Given this list of marker genes Tssk1, Hspd1, Calcr, Gabra2, Klk5, Pam, Exoc3l, Ntf3, Clca1, Atm, Tbc1d21, Hilpda, Resp18, Ccl28, Dynll1, Stx7, Rab27b, Itgb2l, Dennd4c, Serpine1, Stx4a, Stxbp3, Klk1b9, Klk1b27 (NCBI Gene Id 56855), Septin6, Usp8, Defa30, Dvl1, Spata31, Stx12, Elane, Sytl4, Pomc, Slc17a7, Ap2a2, Tsc22d4, Flot2, Rac1, Htr1d, Ecrg4, Ace3, Tmprss4 (NCBI Gene Id 214523), Slc18a3, Krtdap, Amph, Slc30a3, Defa40, Slc35f1, Brsk1, Lyz1, Syndig1, Dlg1, Atp6v0a2, Abhd2, Cav2, Rab7, Knl1, Prkaca, Crh, Spink5, Syt6, Tssk2 (testis-specific serine kinase 2), Txndc8, Rab14, Slc2a13, Hexa (NCBI Gene Id 15211), Sytl1, Try5, Aph1a, Klk1b8, Ddc, Klk11, Mtmr2 (myotubularin related protein 2), Adam2, Pcsk1n, Tmed2, Nos1, Defa36, Eppin, Scnn1a, Catsper3, Iqub, Atg9a (autophagy related 9A), Klk1b3, Tmem190, Cadm1, Brca2, Otof, Atp6v1b1, Slc11a1, Pde4b (NCBI Gene Id 97194), Cep131, Septin14, Igf1, Scg3, Gal, Semg1, Rab8a, Lamp1, Septin5, Snx10, Spaca5, Hyal3, Akap7, Actl9, Prss55, Baiap3, Anxa3, Spaca7, Cd177, Syn1, Acp3, Unc13d, Clu, Prss37, Sec22b (NCBI Gene Id 99656), Tmem184a, Bmf, Tcirg1, Cbarp, Dnm1l, Tmed9, Cylc1, Cyp19a1, Kirrel3, Syt3, Dcst1, Syt5, Ltf, Glipr1l1, Ebag9, Rab10, Cadps, Cct6a, Snapin, Dpysl3, Pcsk4, Pomt1 (protein-O-mannosyltransferase 1), Cln3, Tprg1l, Syt13, Mroh2b, Aqp2, Lamp5, Gria1, Syngr4, Rab4b, Spaca3, Slc9a4, Defa2, Clcn5, Defa5, Defa27, Defb22, Oxt, Astl, Serpina5, Prss58, Itpr2, Npy, Dnajb3, Calr, Spaca6, Zpbp, Pikfyve, Rph3a, Defa3, Snca, Anxa7, Slc17a9, Znrf1, Vamp8, Vdac3, Snap25, Tmem225, Marcksl1, Klk1b1, Wdr7, Slc32a1, Lamp2, Napsa, Prss57, Gars1, Scg2, Cops4, Klk1b11, Pla2g4a, Tssk4, Trpm7, Klk1b4, Unc13a, Arpc2, Sftpb, Lyz2, Actn1, Synpr, Serpine2, Nppc, Rab40b, Map6, Trim9, Vamp1, Scamp5, Pla2g2a, Car4, Trh, Rab5b, Picalm, Spag11a, Gad2, Sh3gl2, Mctp2, Lyzl6, Dynlt4, Scg5, Prss59, Tcp11, Defa25 (NCBI Gene Id 13236), Pcsk2, Spag6, AY761185, Rab5c, Ghrl, Calm3, Stx6, Fas, Tff3, Notch1, Gm14569 (predicted gene 14569), Ica1, Dkkl1, Fabp9, Klk14, Dpep3, Bace2, Pla2g10, Lrp1, Atp6v0e2, Atp6v1e1, Ccdc136, Ngf, Ift74, Vdac2, Ang4, Ece1, Fga, Kif1a, Defa24, Spag8, Klk8, Ap3m2, Ssh2, Lnpep, Vps13b, Atp7a, Btbd8, Defa23, Klk7, Syt2, Vwf, Slc2a8, Plcb2, Izumo3, Bpifa2, Slc40a1, P2rx2, Acr, Phf24, Unc13c, Camp, Ins2, Sytl5, Anxa11, Syt7, Atp8a1, Gnai3, Rab12, Ppt1, Mctp1, Srgn, Fgg, Klk1b21, Gh, Drd2, Sv2a, Klk13, Lypd4, Ncs1, Ncstn, Anxa5, Prl, Pramel1, Dgki, Snap23, Syt12, Gp2, Defa32, Tmem95, Hgs, Pdyn, Atr, Zg16, Stxbp5, Fgb, Defa37, Grin1, Ift88, Pdia3, Syt8, Syt4, Cabs1, Arc, Tmem230, Selp, Grin2a, Exoc3, Pi4k2a, Ghrhr, Kcnc4, App (NCBI Gene Id 319425), Abcc8, Racgap1, Fndc3a, Calm2, Hps4, Defa34, Hexb, Capn11 (calpain 11), Il1b (NCBI Gene Id 16176), Calm1, Klk1b26 (kallikrein 1-related petidase b26), Tcp11x2, Fstl3, Defa20, Spag17, Pak2, Rab37, Klk6, Tgfb3, Atp6v0a1, Cd46, Gabbr1, Cltb, Pebp1, Csnk2a2, Atp6v1d, Slc17a8, Rab4a, Mal2, Scamp1, Bcl2l1, Bdnf, Syt1, Sri, Trim36, Crcp, Spesp1, Atp6v1b2 (ATPase, H+ transporting, lysosomal V1 subunit B2), Myo5c, Tsks, Shh (sonic hedgehog), Dnajc5, Tgfb2, Atp6ap1, Prss40, Syngr3, Spaca9, Rnpep, Ap1b1, Rab13, Arsa, Tmem163, Cyb561, Slc9a8, Sprr2e, Rab6a, Cel, Enkur, Kif3c, Dbi, Atp8b3, Defa41, Abcc9, Mt3 (NCBI Gene Id 17751), Bsn, Cartpt, Rab2b, Pkdrej, Prkn, Atp2b1, Crisp1, Crhbp, Klk9, Defa42, Madd, Slc18b1, Bin1, Rab5a, Ins1, Cttnbp2, Tbxa2r (thromboxane A2 receptor), Sytl3, Itgb1, Septin8, Reg3g, Defa38, Atp6v1c1, Stx3, Ct55, Gnat3, Pla1a, Grp, Defa39, Myh9, Actl7a, Slc22a2, Tor1a, Tex22, Lgi3, Gria2, Calcrl, Mme, Snap91, Slc30a5, Spam1, Spag6l, Sypl2, Bace1, Syngr2, Sh3gl3, Mfge8, Syt15, Atp2c1, Stxbp5l, Defa43, Gkn1, Kcnq1, Slc35d3 (NCBI Gene Id 76157), Syn2, Ap2m1, Smpd1, Dbh, Cfap119, Stxbp2, Atp8b5, Trip11, Actrt1, Slc6a5, Akt2, Wfs1, Atp6v1e2, Cacna2d1, Klk4, Cpe, Syt10, Adcyap1, Fzd8, Cimip4, Vps33b, Clk3, Ptprs, Defa35, Npff, Akap3, Slc6a7 (NCBI Gene Id 240332), Prtn3, Reg3b, Slc17a5, Spx, Atp6v1g3, Iqcf1, Fam170b, Olfm4, Mmrn1, Syn3, Hyal5 (hyaluronoglucosaminidase 5), Padi6, Rab40c, Ap2a1, Slc18a2, Klk12, Hspa8, Tafa4, Doc2b, Ap3s2, Psen2, Rab27a, Slirp, Klk1b16, Rph3al, Sprr2a1, Ctnna1, Sparc, Unc13b, Ptpn5, Ston1, Slc18a1, Trappc4, Atp6v0d1, Atp6v1a, Ube3a, Vps45, Ift20, Ppbp, Sema4c (sema domain, immunoglobulin domain (Ig), transmembrane domain (TM) and short cytoplasmic domain, (semaphorin) 4C), Ly6k, Vamp3, Slc9b2, Golga1, Nudt1, Klk1b24, Dmbt1, Stx1a, Park7, Lyzl4, Syp, Dnase1, Sprr2i, Ccdc62, Rab2a, Mff, Vti1a, Klk10, Osbp2, Dtnbp1, Atp6v1f, Cplx3, Cuzd1, Pick1, Dcst2, Dmxl2, Dld, Npy1r, Ndel1, Klk15, Grin2b, Vti1b, Adrb2, Cxadr, Myrip, Atp6ap2, F5, Capza3, Ston2, Skil, Rab8b, Nkd2 (naked cuticle 2), Doc2a, Gip, Cfp, Ptprn, Moxd1 (NCBI Gene Id 74332), Klk1b22, Cav1, Tnf, Avp, Ctsh, Gck (glucokinase), Morn3, Vdac1, Spaca4, Zp3r, Gcg, Atp6v0c, Ntf5, Omp, Slc6a9, Tmem63b, Stk31, Rnd2, Entpd1 (NCBI Gene Id 72476), Lrguk, Defa26, Penk, Aqp1, Gnai2, Moxd2, Sycn, Adam10, Slc6a17, Fsip1 (fibrous sheath-interacting protein 1), Serpini1, Defa17, Rcbtb2, Fstl4, Sytl2, Catsper4, Pcsk1, Syngr1, Septin1, Syt11, Ptprn2, Acrbp, Prrt2, Rogdi, Cops5, Eqtn, Acrv1, Bsg, Rab3b, Gipc1, Prkg1, Dlg2, Disc1, Gpr151, Tmprss12 (transmembrane (C-terminal) protease, serine 12), Tekt3, Abca12, Rab3c, Cracr2a, Slc2a3, Rab11b, Defa31, Ctsg, Sh3glb1, Clip2, Th, Oprd1, Stxbp1, Anp32e, Spaca1, Tcp1, Sst, Myo5a, Sv2b (synaptic vesicle glycoprotein 2b), Sftpc, Svop, Cltc, Klk1, Scgb1a1, Slc17a6, Igfbp3, Itga1, Sprr2g, Slc2a4, Sv2c, Cypt1, Cfap65, Vegfa, Itpr3, Atp6v0a4, Chgb (NCBI Gene Id 12653), Plat, Clta, Kcnk9, Rab26, Cyp51, Pate4, Clcn3, Sprr2a3, Itpr1, Htr7 (NCBI Gene Id 15566), Prrt1, Ica1l (islet cell autoantigen 1-like), Rabac1, Spata1, Rab35, Rab3a, Col1a1, Bicd1, Angptl6, Abcc4, Slc30a2, Il4i1, Zpbp2, Apc (APC, WNT signaling pathway regulator), Cabp1 (calcium binding protein 1), Baiap2, Cadps2, Slxl1, Slc5a7, Snap29, Dlg4, Reg1 (NCBI Gene Id 19692), Sprr2d, Slc4a8, Sod1, Syt17, Prss39, Hcrt, Morn2, Sgta, Stx16, Atp6v1g1, Slc6a2, Rnf112, Mylk2, Vps13c, Syt9, Tuba8, Mpo, Slc35g2, Fam220a, Spink2, Pla2g1b, Adam8, Phaf1, Erc1, Slc10a4, Sphk1, Adam15, Ogt, Atp6v1h (ATPase, H+ transporting, lysosomal V1 subunit H), Edn1, Kit, Vamp2, Creb3l4, Hap1, Rab3d, Dmd, Borcs5, Defa28, Izumo1, Kcnj11, Pnliprp2, Ppfia2, Adrb1, Iqsec1, Cma1, Treml1, Vps13a, Vezt, Cdk16, Septin4, Slc30a8, Oprk1, Sun1, Chga, Ppfia3, Dnm1, Thbs2, Tmed10, Sypl1, Kif1b, Pf4, Anxa4, Sptbn2, Lrrk2, Spata16, Atp6v1g2, Prss51, Psen1, Ncf2, Nlrp5, Klk1b5, Loxl1, Thbs1, Calca, Abca3, Cdc42, Tmem210, Lamp3, Tex101, Ctsl, Rab11fip5, Exoc4, Clcn4, Tgfb1, here is a description of the gene set: Mouse Gene Set: GOCC_SECRETORY_VESICLE species: Mus musculus A cytoplasmic, membrane bound vesicle that is capable of fusing to the plasma membrane to release its contents into the extracellular space.